Given this list of marker genes FUT2, SUPT4H1 (SPT4 homolog, DSIF elongation factor subunit), MPP2, ASMT, TTC1, CSTF3, APOC3, TMEM106A, RING1, FANCC, AAMP, BNIP1, HMGA2, TIMM17A, COX10, TP53BP1, DGCR6, ADCYAP1, SMARCD1 (NCBI Gene Id 6602), ODF1, PRKAG1, SDHC, POLR1HASP, DPF2, ZNF8, VPS72, RFX5, DRG2, PMS2P11, GRM4, BCAT2, TAF1, here is a description of the gene set: Neighborhood of DPF2 studied in species Homo sapiens Neighborhood of DPF2 D4, zinc and double PHD fingers family 2 in the GCM expression compendium Human Gene Set: GCM_DPF2